Given this list of marker genes NR5A2, CYP21A2, BMP5, CYP11B1, NR3C1, BMP2, H6PD, REST, DKK3, DGKQ, CYP17A1, CYP11A1, ATP1A1, WNT4, CYP11B2, SERPINA6, CRH, CACNA1H, here is a description of the gene set: Human Gene Set: GOBP_GLUCOCORTICOID_BIOSYNTHETIC_PROCESS studied in species Homo sapiens The chemical reactions and pathways resulting in the formation of glucocorticoids, hormonal C21 corticosteroids synthesized from cholesterol.